The following is a description of a gene set: Mouse Gene Set: XIE_TRASTUZUMAB_CARDIOTOXICITY_MMU_MIR_3095_3P_GENES Abstract: Trastuzumab-induced cardiotoxicity (TIC) is a common and serious disease with abnormal cardiac function. Accumulating evidence has indicated certain non-coding RNAs (ncRNAs), functioning as competing endogenous RNAs (ceRNAs), impacting the progression of cardiovascular diseases. Nonetheless, the specific involvement of ncRNA-mediated ceRNA regulatory mechanisms in TIC remains elusive. The present research aims to comprehensively investigate changes in the expressions of all ncRNA using whole-transcriptome RNA sequencing. The sequencing analysis unveiled significant dysregulation, identifying a total of 43 circular RNAs (circRNAs), 270 long noncoding RNAs (lncRNAs), 12 microRNAs (miRNAs), and 4131 mRNAs in trastuzumab-treated mouse hearts. Subsequently, circRNA-based ceRNA networks consisting of 82 nodes and 91 edges, as well as lncRNA-based ceRNA networks comprising 111 nodes and 112 edges, were constructed. Using the CytoNCA plugin, pivotal genes - miR-31-5p and miR-644-5p - were identified within these networks, exhibiting potential relevance in TIC treatment. Additionally, KEGG and GO analyses were conducted to explore the functional pathways associated with the genes within the ceRNA networks. The outcomes of the predicted ceRNAs and bioinformatics analyses elucidated the plausible involvement of ncRNAs in TIC pathogenesis. This insight contributes to a better understanding of underlying mechanisms and aids in identifying promising targets for effective prevention and treatment strategies. studied in species Mus musculus from publication Xie S, Zhou N, Su N, Xiao Z, Wei S, Yang Y, Liu J, Li W, Zhang B (PMID 38577019), and this is the list of marker genes: Glod4, Gtf2i, Gcsam, Limk1, Syt3, Plekhm2, Smpd4 (sphingomyelin phosphodiesterase 4), Dip2a (NCBI Gene Id 78897), Il6st, Sorbs3, Celf1, Grk6, Hlcs, Nol4l, 1700030J22Rik, Adipor2, Pitpnm3, Tpm3, Traf7, Dand5, Zmynd11, Naa30, Gabpb2 (NCBI Gene Id 99849), Dusp3, Chfr, Arrb1, Map3k13, Etv3, Flnc, Src, Sec16b, Dock3, Epb41l5, Rac1, Ednrb, AW554918, Gatad2b, Tbl1xr1, Stk38l, Ate1, Mapk10, Tspan5, Gm1979, Hdhd2, Tom1l2, Zfp811, Rcc2, Mettl14 (NCBI Gene Id 210529, methyltransferase 14, N6-adenosine-methyltransferase subunit), Pml, Rimbp2, Rab22a, Bend4, Clec16a, Rgs12, Trim2, Zbtb5, Adcy7, Ahcyl2, Kcna6, Fkbp5, Rfc1, Tcf24, Clmn